Given this list of marker genes Nup205, Nsa2, Pld1, Gprc5c, Skint3, Spata1, Tardbp, Haao, Lrig2, Cnot2, Ptchd4, Ehmt1, Tmem41b, Gal3st2, Gimap4, Tph2 (NCBI Gene Id 237554), Cdh11, Fam20a, Apcs, Socs2, Plppr5, Taok1, Col25a1, Dcc, Zfp608, Tmpo, B3gat2, Gls2 (NCBI Gene Id 216456), Srek1, Tgm3, R3hdm1, Nr2e1 (nuclear receptor subfamily 2, group E, member 1), Scp2, Vezf1, Cul3, Gp6, Nampt, Ifi211, Chac1, here is a description of the gene set: Mouse Gene Set: MIR_219B_5P species: Mus musculus Genes predicted to be targets of miRBase v22 microRNA mmu_miR_219b_5p in miRDB v6.0 with MirTarget v4 prediction scores > 80 (high confidence targets). from publication Chen Y, Wang X (PMID 31504780)